Given this list of marker genes TIPARP, CDH1, ZCCHC10, TMEM132C, TSPAN9, TREML4, TUBA3C, TCP1, SMKR1, TRAPPC5, HJURP (Holliday junction recognition protein), C12orf42, TIRAP, CDCA2, ENTPD4, DCPS, CC2D2B, MASTL, SOX12, P4HA2, ARHGEF28, EGLN3, MPP2, DNAH11, LPL, TEX9, C15orf48, LRRC31, MESP2, BUB1B, MCPH1 (microcephalin 1), GRHPR, FGGY, DAPK2, CDIN1, TBC1D31, THSD1, GZMB, CYSLTR1, NAT8L, CCDC115, LMAN2L, BAG2, ANGPTL4, RNF112, TFAP4, TCEAL1, AMZ1, SIVA1, SPATA19, NYAP1, GCNT1, UBE2U, RCBTB2, LAGE3, DOCK7, DSC1, SPATA2L, SASH3, MSX1, SCRG1, KIFC2, BASP1, HPCAL1, DUSP9, HRC, ASCL2, F12, DLEU7, PADI2, RGS6, THEMIS, LHX1, MAN1C1, NFATC2, TUBB, MS4A18, CD72, CABCOCO1, STARD4, ARHGEF39, CHSY1, THEM5, NOPCHAP1, SLC22A6, FDX1, TXN, MFSD10, MBNL2, BVES, LIMS4, PSAT1, RNF26, PYGL, DOK1, OGFOD3, HS1BP3, RNASE4, FMO2, PILRB, BBS5, ACAT2, TP53TG5, AHCYL1, AURKB, MED12L, ZNF428, PLEKHH3, MCTP1, LSS, TSR3, SELENBP1, MGMT, SPMIP6, CHCHD6, ZNF334, RAD51AP1, SNUPN, MIA2, CPSF4, CD93, ANG, CERCAM, DMP1, GPATCH11, RELL2, IL22, ZBTB12, PLOD2, LY6K, C9orf85, C6orf132, AP3S1, KGD4, PAOX, TOP1MT, PCDHAC1, ERP29, RIT1, SSR1, BRK1, RCOR2, SEPTIN6, FOXI1, FKBP1B (NCBI Gene Id 2281), TSPAN18, NR2F1, ADSS1, SPOCK2, AQP9, TTC23L, RASEF, CDCA7L, COX10, FNDC4, SPRY4, TMEM107, ATG9B, MYOC, KLF9, NUBPL, PRELID2, HACD4, FGFBP1, EGFL7, HACD1, PLEKHF1, CCDC172, MBOAT1, LRRC59, NFIL3, ARMC2, GMDS (GDP-mannose 4,6-dehydratase), GLOD4, TFR2, KCNT2, RALB (RAS like proto-oncogene B), C8G, RAB3A, S100A9, NEMP1, C16orf78, CDC16, MAZ, TMPRSS5, PPIL6, RHOB, INHA, ANXA1, MTFP1, MYL11, RNASE10, EXTL1, TSPAN4, RDH12, ADGRG5, GPD1, PGP, TSGA10, ACP1, here is a description of the gene set: studied in species Homo sapiens Genes down-regulated in comparison of CD4 T cells activated with lamina propria dendritic cells versus regulatory T cell (Treg). CD4(+)Foxp3(+) regulatory T (Treg) cells originate primarily from thymic differentiation, but conversion of mature T lymphocytes to Foxp3 positivity can be elicited by several means, including in vitro activation in the presence of TGF-beta. Retinoic acid (RA) increases TGF-beta-induced expression of Foxp3, through unknown molecular mechanisms. We showed here that, rather than enhancing TGF-beta signaling directly in naive CD4(+) T cells, RA negatively regulated an accompanying population of CD4(+) T cells with a CD44(hi) memory and effector phenotype. These memory cells actively inhibited the TGF-beta-induced conversion of naive CD4(+) T cells through the synthesis of a set of cytokines (IL-4, IL-21, IFN-gamma) whose expression was coordinately curtailed by RA. This indirect effect was evident in vivo and required the expression of the RA receptor alpha. Thus, cytokine-producing CD44(hi) cells actively restrain TGF-beta-mediated Foxp3 expression in naive T cells, and this balance can be shifted or fine-tuned by RA. from publication Hill JA, Hall JA, Sun CM, Cai Q, Ghyselinck N, Chambon P, Belkaid Y, Mathis D, Benoist C (PMID 19006694) Human Gene Set: GSE13306_LAMINA_PROPRIA_VS_SPLEEN_TREG_DN